The following is a description of a gene set: Human Gene Set: MIR30B_5P_MIR30C_5P species: Homo sapiens Genes predicted to be targets of miRBase v22 microRNA hsa-miR-30b-5p, hsa-miR-30c-5p in miRDB v6.0 with MirTarget v4 prediction scores > 80 (high confidence targets). from publication Chen Y, Wang X (PMID 31504780), and this is the list of marker genes: BDP1, SRSF7, CCNE2, ELOVL5, YAF2, LRP6, ASB3, ZBTB18, ZBTB11, GMNC, SEC22C, CEP15, DDIT4, GNA13, MARCHF8, PPARGC1B, PSMD7, AGO3 (argonaute RISC catalytic component 3), ADGRA3, NAALADL2, FBXL20, FAM13C, CAMK4, AVL9, PIP4K2A, CRACDL, LRRK2, DIPK2A, LRRC8D, SLC25A21, PPID, CHD7, MAP3K13, YY2, MROH9, CARF, GOLGA6C (NCBI Gene Id 653641), ZNF711, VIM, TOGARAM1, ADAMTS6, PCGF5, PDE7A, CNOT6, GOLGA1, ZNF519, LIN28B, EPB41 (erythrocyte membrane protein band 4.1), FNDC3A, MLXIP, PPP1R18, RAVER2, LCLAT1, RNF122, ANKRA2, NHLH2, NRG3, WDR82, FBXL17, TLL2, NEURL1B, TASP1, SLC38A2 (NCBI Gene Id 95454), CCDC43, WASHC4, MARCHF6, SAMD8 (sterile alpha motif domain containing 8), WDR44, CFL2, TNIK, PLEKHO2, CERT1, CHST1 (NCBI Gene Id 8534), SOCS3, KMT2C (NCBI Gene Id 80260), DPY19L3, ARHGAP29, NR5A2, MAST4, CAMK2D, TENM3, MAP4K4, EXTL2, CCDC120, SCML1, MFSD6, IDH1, RHD, IRX4, NFIB, SH3RF1, CELSR3, ROR1, SYPL1 (synaptophysin like 1), HDAC9, SEPTIN8, SEC23A, PTP4A1, TFDP1, SLC6A6, STT3B (NCBI Gene Id 201595), PNPLA1, GOLGA4, CBX2, TULP4, PTGFRN, DPY19L1, TMCC1, PRDM13, DDX59, TENT2, GLCCI1 (NCBI Gene Id 113263), RFX3, FZD3, OTUD4, GFPT2, LINC03034, STK39, ARID4A, EXOC6, LRCH2, CMTM4, CARS1, ALG10, BCL2L11, HCFC2, UBE2V1, PDGFRB, IL1RAPL2, ERICH3, BAHD1, MIA3, RUNX2, S100PBP, ZFAND5, VAT1L, ATG5, ATXN1, FNIP2, PER2, MBNL3, DNMT3A, YTHDC1, THAP12, NSG1, KCTD16, ATG12, HBS1L, SMDT1, PHIP (NCBI Gene Id 83843), PDCD10, MAP3K2, MARCHF4 (NCBI Gene Id 57574), PGP, CEP170, CBFB, ZNF704, SAP30BP, MAP3K5, ST8SIA4, TTLL7, DLGAP1, PSD3, VKORC1L1, ERG, RAB32, SACS, MMD, OGA, EEA1, PPP3CA, DPYSL2 (dihydropyrimidinase like 2), NDUFC2, EDEM3, ARID1A, CADM2, RAPH1, TOX, C4orf19, KATNBL1, RAB27B, ADAM12, SLC9A8, CCDC117, TWF1, DENND1B, KCTD8, A1CF, PRPF40A, OMG, MPZL3, HNRNPUL2, ARAF, MXRA5, RASA1, NR6A1, SLC35C1, YTHDF3, GALNT7, TNXB, RALGPS1, MBOAT1, FAP, CHL1, DSTYK, B3GNT5, FAM13A (NCBI Gene Id 389211), EED, ELAVL4, LIFR, NFATC2, HIPK2, USP37, ADRA1D, RTKN2, MYH11, RAPGEF2, ABCC9, ZBTB6, DCTN4, ASB2 (ankyrin repeat and SOCS box containing 2), SNX33, EPG5, GPR19, TENM1, PPARGC1A, CNST, SMAP1, DMXL2, RHEBL1, NAP1L2, TP53INP1, PPP1R9A, ITGA8, PALM2AKAP2 (PALM2 and AKAP2 fusion), PRICKLE1, BNIP3L, FAM133A, PICALM, SRGAP3, ZCCHC2, ASB4, BCL11B, DNAJC25-GNG10, SDK2, PLIN3, SEPTIN7, CAPZA1, BRWD1, DCUN1D1, ACTR1A, EPC2, GCLC, CTHRC1, ZDHHC17, LPP (LIM domain containing preferred translocation partner in lipoma), CAMKK2, STOX2, SCN1A, UBN2, SLC4A7, OSTM1, ADGRL3, RIMBP2, EEF1A1, MAML1, LCORL, RORA, RAB2A, WIPF3, ADRA2A, PDSS1, SSH2, CACHD1, CCDC6, RAB8A, P4HA2, NFATC3, NCAM1, MYO5A, TRAPPC14, NEFM, CPEB3, SOCS6, CLOCK, JPH4, ZCCHC3, FHIP2A, EDNRA, ERRFI1, SMAD1, TMEM170B, SNAI1, TNRC6B, DLG5, IDE, MIER3, ZBTB44, IQCB1, ME1, TBC1D2B, SRSF10, UBE2V2, ARMH3, CYB561, MAT2A, USP2, ERLIN1, SLC35F3, KCNA4, GMEB2, C9orf72, TCIM, CCDC97, R3HDM1, MTDH, PLPP6, SHISA3, ADAM19, SOX13 (NCBI Gene Id 9580), SAMTOR, ZNRF1, TNRC6A (NCBI Gene Id 92763), CNKSR2, MAPK8, ARHGAP26, NKX2-2, TDG, CPNE8 (NCBI Gene Id 144402), PPP3CB, CERS6, MKRN3, SNAI2, TAF4B, CHD1, PRUNE2, DCUN1D3, SEMA3A, ACTC1, ATP2A2, KIF11, ADAMTS9, OSBPL8, ABL1, PEX5L, LMLN, RTN4IP1, TTBK1, FGD6, ZEB2, RAP1B, NEUROD1, EIF5A2, NHS, STK17B, LIMCH1, ZNF518A, ZBTB41, SCARA5, DNAJC13, MARK1, GPCPD1, DOK5, SLC25A36, ZNF280B, PTPN2, TBL1XR1, GLI2, ANKHD1, PHTF2, UBE3C, AP4E1, ALG10B, CAMK2N1, RAB15, CCNT2, TMEM87B, WWP1, SNX16, PDE4D, KLF9, MAB21L1, PIGA, MZT1, FKBP3, DLGAP4, CEP41, MBTPS2, PPP1R1C, GNG10, STXBP5, STRIP1, MAP6, YPEL5 (NCBI Gene Id 51646), NR4A2, ZFAND1, SNX18, DESI2, PPTC7, SCN9A, SLC7A10, SLCO6A1, JDP2, SNX8, GNAI2, ZPBP2, CADPS, SKP2, TNRC6C, IP6K3, PLA2G12A, MEOX2, ADAM9, RRAS2, NADK, PHF13, GATM, ZNF521 (zinc finger protein 521), NUP93, IFNAR2, FBXO34, LPGAT1, LMBR1L, C14orf28, APBA1, TUT7, OVOL1, LOX, BCL9 (NCBI Gene Id 607), ELMOD2, SETD7, SCAF4, CNOT9, FAM83F, GALNT2, PTPN13, DOCK7, RAI14, NT5E, HOXA1, TENT5A, BRAP, KSR1, FRZB, ARHGEF6, ANKRD17, SHOC2 (SHOC2 leucine rich repeat scaffold protein), KLHL20, PIK3CD, LGI1, GRM5, PNKD, SCN8A, TRIM13, SH3PXD2A, ABHD10, MAFG, EFNA3, GARRE1, TTLL2, AVEN, KXD1, SLC12A6 (solute carrier family 12 member 6), HIVEP1 (HIVEP zinc finger 1), ZNF286A (NCBI Gene Id 93513), NAPG, LRRC8C, RASA2, IL36RN, PROSER1, KLF12, PPP1R2 (NCBI Gene Id 5504), E2F7, TMEFF1, CHST2, TBC1D10B, KLHL28, WIPF1, HYCC2, RUNX1, LARGE1, FAM110B, ORC2, ATL2, FBXO45, LYRM7, OXR1, TMEM181, KIAA0408, ZNF22-AS1, JOSD1 (NCBI Gene Id 9929), GAREM1, DACT1 (NCBI Gene Id 51339), FAM43A, RAD23B, GRB10, KIAA1549, NRIP1, SOCS1, BNC1, KLF10, CRKL, TMOD2, REEP1, RBM12, PGM1, TSEN15, FAM210B, STAC, LRRC40, PRLR, TM4SF20, RNF157, SETD5, UBE2J1, LIN28A, TM4SF1, FAM91A1, PRKAA2, PDS5B, KLF8, JADE3, YPEL2, AFAP1L2, PLEKHM3, LRRC17, RTN4R, FLVCR2, ZNF507, KCTD7, BRD10, GRM3, RGS8, AZIN1, STX16, BCOR, DLL4, MSI2, RUNDC3B, ITGB3, UBN1, LHX8, INO80D, ARK2C, CSAD, FBXO32, GALNT1, MEIOB, MRPL19, CYP3A5, UBAC1, PPP1R12A, LRFN2, ZNF644, EDC3, SLC35A3, CPSF6, GIGYF1, GJA1, MEX3B, NEFL, ELAVL2, ATP2B1, RAB38, ELL2, SCEL, CSGALNACT1, IRF2BP2, CDCA7, GOLGA8A, MAP3K7, STK35, PAWR, POLR3E, LATS2, TLCD4, STX2, RAB23, GDE1, EML1, MYBL2, PIEZO2, USO1 (USO1 vesicle transport factor), NDEL1, ELOVL2, ESCO1, NF1, STIM2, NAV3, PLPPR4, BNC2, ATOSA, PCMTD2, RALGDS, ACVR1, KDM3A, IGF2R (NCBI Gene Id 3482), CAND1, ZNF608, LYPLAL1, P4HA1, RRAD, GNPDA1, RAPGEF4, RAP2C, GRIA2, MAST3, PRDM1, ACTR3C, NUS1, SIX4, CYP24A1, CCNA1, CEP350, NUFIP2, TTC8, PPP3R1, SLC25A34, STAG2, UGT2A3, LRRC8B, SOX9, TMEM229A, RNF220, NFAT5, PAX3, SP4, USP48, WDR7, TBC1D15, COL25A1, BCL10, GPT2, PCDH17, FLVCR1, TRIO, SUV39H2, COL13A1, SYNGR3 (synaptogyrin 3), UNC5C, ITGA6, ATRN, SCYL3, RASD1, LYN, CDC37L1, MYO1H, PGM3, SEC61A2, EML4, SNTB2, ARID5B, FOXG1, ANO4, IRS1, PDXDC1, AFF4, SCN3A, TMEM87A, KIF16B, CUL2, SPAST, VPS26B, FAM199X, ITPK1, CALCR, SPEN, NAA25, RARG, MCF2L, NUCKS1, SIX1, ADAMTS3, JAKMIP2, NEDD4, VAT1, SCN2A, RFX6, COL9A3, FAM229B, CD2AP, NLGN1, ZFC3H1, IRF4, GABRB1, RAB4B, XPR1, PAAF1, GLDC, FRMD6, KPNA6, SLC30A4, OTUD6B, CAPN5, XPO1, BRWD3, SAMD4A, CFAP97 (NCBI Gene Id 57587), REEP3, RARRES1 (retinoic acid receptor responder 1), ZXDA, PAPOLB, VOPP1, CBLB, WDR64 (NCBI Gene Id 128025), MAP3K21, PPP4R4, NECAP1, DSG2, INPP4A, BRD1, SDAD1, CECR2, RPRD1A, FIGN, PTPDC1, CDK12, TAOK1, MFHAS1, CSNK1A1, ANXA2R, TAB3, TEPSIN, GRIN2A, YOD1 (YOD1 deubiquitinase), ADO, GSKIP, SLC35F1 (NCBI Gene Id 222553), SLC35B4 (NCBI Gene Id 84912), HIC2, DOLPP1, MEX3C, PFN2, HACE1, ZMYND8, CSNK1G1, SPOCK3, TSPAN2, TRPM7, BECN1, RFX7, PAPOLA, SNX10 (NCBI Gene Id 29887), CAMK2N2, PRG4, FRMPD1, CACNB2, SLC5A3 (solute carrier family 5 member 3), SEC24A, MED12L (mediator complex subunit 12L), MAN1A2, UBE2I, CCNK, ZNF382, PHACTR2, SEMA6B, KRAS, PIP4K2B, NCALD, DGKH, ZFY, MIER2, SH2B3, PON2, CALU, DDAH1, ATF1, ADAM22, MTCL2, CDH20, FOXD1, SLC38A7, CHMP2B, ADGRA2, CCNJL, LMBR1, PAXBP1, GIGYF2, RHOB, LHX1, KMT2A (lysine methyltransferase 2A), NTNG1, PLAGL2, PI4K2B, CHIC1